Given this list of marker genes S100PBP, SLC22A15, CRISP1, NABP1, PFN1 (NCBI Gene Id 5216), PLAUR, MFSD11, SLC66A3, TACC1, GALNT2, ZBTB48, CFAP47, FASTKD5, TECPR1, FLOT1, FHOD1, FLI1, H2AB2, UBN1, VPS13D, MYO1E, RPS6KA5, MXRA7, AP5Z1 (adaptor related protein complex 5 subunit zeta 1), EHD3, MROH1 (maestro heat like repeat family member 1), DZANK1, ATG13 (NCBI Gene Id 9776), CYTH4, FAM89B, GPR132, EYA2, ARHGEF4, CISD3, CLDND2, RAPGEF1, KIN, PLEKHJ1, LTO1, FAM78A, GOSR1, SELP, ZNF281 (NCBI Gene Id 23528), USP37, BORCS7, PRR14, EPC2 (enhancer of polycomb homolog 2, NCBI Gene Id 96643), CIRBP, NFKBIE, ZNF251, MBNL2, LRIG2, KLHL28, CYRIA, SSR2, SMAD7, TWF1, DNAJC15, GCN1, ATP9B, OPLAH, NIPAL3, SMURF2, TTF1, FLT1, HCK, NUDT16, C2orf68, SPPL2A, SLC11A1, ITCH, NOS2, TOMM34, ZC3H10, TRAF3, RIMBP3C, SEPTIN9 (septin 9), L1CAM (L1 cell adhesion molecule), VAV1, ALDH18A1, ANKLE2, MMP8, GBP6, PRR14L, GMIP, G6PD, TMEM18, MIER2, UCKL1, TTC39C, FAAP24, KIDINS220, TRAPPC1, UBA7, CEPT1, FRS2, HPS3, ELANE, FHL2, DNAJA4, USP49, CLEC2L, ZNF652 (zinc finger protein 652), ZFP3, GID8, TMEM120A, ZDHHC24, CNR2, TACC2, SLC25A11, ING3, EML2, MOB4 (NCBI Gene Id 96815), PHF1, RABAC1, NMT2, RIDA, SQOR, MAT2A (NCBI Gene Id 4144), GSK3B, DDX31, NANS, LMNA, GINM1, DBR1, VASP, ERCC4, FOXD4L1, STK38, ARL5A, COL6A3, ZNF585A, ZBTB33, FMO5, ZNF324B, WSB2, ST8SIA3, C10orf88, GXYLT1, ANAPC2, TBRG1, VCPIP1, ZNF2, ELK3, BET1L, TMEM80, TSTD1, IKBKG, IL3RA, CD300LB, KANSL3, SLC37A3, PSME2, DIAPH2, SLC44A2, CCDC82, STX5, BCL2A1, TRAPPC2, GPS2, STX7 (NCBI Gene Id 8417), TTC9C, DPF2, HCLS1, GGNBP2, FOXL1, PIGC, FBXO11, RUFY3, PDLIM7, RFNG, DBP, RNF125, NR4A1, COMMD4, TRNT1, MMP9, TSHZ3, ADAR, CDC14B, FGD1, SLC35F5, SSBP4, SLC39A4, PKD2L2, WASHC2A, EXOC2, FAM149B1, USP24 (ubiquitin specific peptidase 24), ITPR3, PPP1R21, AGPAT3, SCAMP2 (NCBI Gene Id 10066), RGP1, CREBBP, BCAS3, PARP3, NAGA, VSIG10, IL36G (NCBI Gene Id 56300), here is a description of the gene set: Genes down-regulated in IRF4 and IRF8 null pre-B cells treated with 0.25 ng/ml IL7 versus the cells treated with 5 ng/ml IL7 and transduced with IRF4. Productive rearrangement of the immunoglobulin heavy chain locus triggers a major developmental checkpoint that promotes limited clonal expansion of pre-B cells, culminating in cell cycle arrest and rearrangement of the kappa (κ) or lambda (λ) light-chain loci. B lineage cells lacking the related transcription factors IRF-4 and IRF-8 undergo a developmental arrest at the cycling pre-B cell stage and are blocked for light-chain recombination. Using Irf-4,8-/- pre-B cells we demonstrate that two pathways converge to synergistically drive light-chain rearrangement, a process that is not simply activated by cell cycle exit. One pathway is directly dependent on IRF-4, whose expression is elevated by pre-BCR signaling. IRF-4 targets the κ 3′ and λ enhancers to increase locus accessibility and positions a kappa allele away from pericentromeric heterochromatin. The other pathway is triggered by attenuation of IL-7 signaling and results in activation of the κ intronic enhancer via binding of the transcription factor, E2A. Intriguingly, IRF-4 regulates the expression of CXCR4 and promotes the migration of pre-B cells in response to the chemokine CXCL12. We propose that IRF-4 coordinates the two pathways regulating light-chain recombination by positioning pre-B cells away from IL-7 expressing stromal cells. We used microarrys to identify the changes in gene expression under different levels of the cytokine IL-7 and after rescue of genetic defect. Human Gene Set: GSE10273_LOW_IL7_VS_HIGH_IL7_AND_IRF4_IN_IRF4_8_NULL_PRE_BCELL_DN studied in species Homo sapiens from publication Johnson K, Hashimshony T, Sawai CM, Pongubala JM, Skok JA, Aifantis I, Singh H (PMID 18280186)